Given this list of marker genes RNU4ATAC, NOTCH3, DNAJC19 (DnaJ heat shock protein family (Hsp40) member C19), STT3A, SLC30A9, PUF60, RAB3GAP2 (RAB3 GTPase activating non-catalytic protein subunit 2), GANAB, WAC, CTCF, NRCAM, EIF4A2, NEK1, KRAS, RTTN, AXIN1, ADAT3, NARS1, DENND5A, PI4KA, IFT140, WLS, CPLANE1, OTUD5, SH2B1, OFD1, AHDC1, FOXC2, PUS3, NRAS, FGFR1, XPNPEP3, HRAS, RNU4-2 (RNA, U4 small nuclear 2), ALKBH8, PDGFRB, SHANK3, ARID2, BICC1, PLK4, FGFR2, ALG9, DHCR7, ZFX, GPSM2, PKD1, ITPR1, SCN2A, ZNFX1, PKD2, CCDC22, PPP2R5D, SCN1A, ATP6AP1 (NCBI Gene Id 537), NSD1, KCNC2, DNAJB11, SACS, SON, ALG5, ZIC2, EBP, here is a description of the gene set: Abnormal arachnoid mater morphology Human Gene Set: HP_ABNORMAL_ARACHNOID_MATER_MORPHOLOGY studied in species Homo sapiens An abnormality of the Arachnoid mater.